The following is a description of a gene set: Human Gene Set: GOBP_MONOSACCHARIDE_TRANSMEMBRANE_TRANSPORT studied in species Homo sapiens The process in which a monosaccharide is transported across a lipid bilayer, from one side of a membrane to the other. Monosaccharides are the simplest carbohydrates; they are polyhydric alcohols containing either an aldehyde or a keto group and between three to ten or more carbon atoms. They form the constitutional repeating units of oligo- and polysaccharides., and this is the list of marker genes: SLC2A12, NR4A3, RSC1A1, TRARG1, LEP, GH1, CTNND1, C1QTNF12, TRIB3, SLC2A10, PPBP, CLIP3, MIR103A1, SLC5A9, SELENON (selenoprotein N), PRKCI, SLC2A1, SLC2A14, BRAF, MAPK14, HK2, EDN1, HNF1A, PIK3R1, MIR107, CREBL2, SLC5A10, SLC23A2, SLC2A9, SLC2A3, OSTN, MEF2A, SLC45A1, SORBS1, PID1, RAB4B, FGF21, ENPP1, SELENOS, FABP5, MIR223, SLC45A2, SLC27A1, YES1, MIR143, PTPRM, INPP5K, SLC2A5, SLC5A1, SLC1A2 (NCBI Gene Id 6506), GPC3, SLC2A2, SLC2A8 (NCBI Gene Id 29988), C3, GSK3A, TERT, SLC2A7, TNF, OCLN, IRS1, SLC5A2, PLA2G1B, APPL2, CERS1, DHRS7C, RHOQ, CAPN10 (calpain 10), SORT1, POU4F2, SLC26A5, INS, ASPSCR1, SGCB, RTN2, SLC23A1, SLC27A4, SLC5A11, SLC50A1, IRS2, SIRT6, APPL1, ITLN1, ADIPOQ, SLC2A11, SLC5A3, C2CD5, CD2AP, SESN2, PTH, SLC2A6, PEA15, OPN3, IGF1, PRKAG2, RAP1A, FGF19, OSBPL8, ZDHHC7, SLC45A3, PRKCB, PTPN11, STXBP4, SLC2A4, AKT2, KLF15, ACACB, SLC25A27, CLTCL1, FFAR4, INSR, IL1B, GRB10, AKT1, RNASEL, DRD1, STXBP3, ERFE, PPARD, NFE2L2, TSC1, ARPP19, EDNRA